The following is a description of a gene set: from publication Shinohara H, Behar M, Inoue K, Hiroshima M, Yasuda T, Nagashima T, Kimura S, Sanjo H, Maeda S, Yumoto N, Ki S, Akira S, Sako Y, Hoffmann A, Kurosaki T, Okada-Hatakeyama M (PMID 24833394) Human Gene Set: GSE41176_WT_VS_TAK1_KO_ANTI_IGM_STIM_BCELL_6H_DN studied in species Homo sapiens Genes down-regulated in B lymphocytes treated by anti IgM for 6h: wildtype versus MAP3K7 knockout. The activation signaling of transcription factor nuclear factor-kB (NF-kB) plays central role for immune system. One of key kinase mediating this pathway is TAK1 in adaptive and innate immunity. However, role of TAK1 in B cell receptor signaling is still unclear. To know effects of TAK1-deletion on the gene expression induced by anti-IgM, we performed the time course analysis in comparison of wild type with TAK1-deleted splenic B cells., and this is the list of marker genes: PLSCR1, PTPN6, PATZ1, COPS7A, FH, TRAF3IP2, RIPK2, DENND4A, ZNF10, SUCLA2, HCAR3, STAT1, RAC2, IFNGR2, IVNS1ABP, IFNGR1, M6PR, PFDN1, TADA3, SERBP1, RABGGTB, PTGS2, FLOT1, ADAMDEC1, TNFAIP3, PIM2, UTP3, TNIP1, RIN2, COQ2, C3AR1, PDHX, KYNU, CYRIA, RAD23A, GCH1, SHMT2, IL4R, FCHSD2, RPE, CLK2, DNAJC11, DDX18, ACO1, SUSD6, IFNAR2, NBN, TRAFD1, ADAR, TUBB, EIF3M, TFEC, BECN1, B2M, IL2RG, VPS11, PTX3, SERPINB9, LSS, GGCT, SERPINB1 (NCBI Gene Id 1992), BIRC3, RUVBL2, TFRC, BATF, CD80, INSIG1, ADORA2A, IKBKB, ANKS1A, CFLAR, BCL2A1, AK4, PISD (NCBI Gene Id 29838), NFKBIA, KCNMB1, IQGAP2, PUM3, PLD1, PSMA6, DMXL2, FNBP1, SASH1, DYRK3, KANK1, CDK4, NR3C1, NFKB1, STAT5A, ENG, MSC, ARFRP1, HCK, POLR1C, GBP1, SOCS3, ZNF175, ZC3H13, RAB3GAP1, ZFYVE26, GSDME, HDGF, DYNC1I2, TNFAIP8, CD40, NCAPD2, MRPL9, N4BP1, LYN, EIF2B2, C5orf15, ALDH9A1, IGSF6, NAB1, SMS, ADA, PTEN, LAMP3, TFDP1, BMS1, RHOQ, CRIM1, ACSL4, LPL, ACP2, RGS19, BTG3, MAP3K4, GRB2, RAB13, FLT1, FARSA, GGA3, CREBL2, CEP135, UBE2D1, NECAP1, ATP6V1H, CD69, CD44, POLR2J, ARAP1, GPSM3, SLC39A8, BBS4, PDE4B, ATP6AP1, NDUFV2, ZNF330, HAX1 (HCLS1 associated protein X-1), ITGA1, AMPD3, MAP3K5, TBC1D9, CASP1, CDK14, DUSP2, ALCAM, MLH1, RFTN1, ARFIP1, TNFRSF4, SLC11A2, PTAFR, AKAP10, CD47, DDX19B, LPP, ADGRE2 (adhesion G protein-coupled receptor E2), AQP9, IL18, MAK16, NUP188 (nucleoporin 188), LAIR1, ZBTB24, ATP6V0A2, CD48, GPR137B, PTPRJ, HLA-F, G0S2, SGPL1, ATP2C1, ATP6V1E1, RARS1, STAT4, BOLA2, AIMP2, GSK3B, EPM2AIP1 (NCBI Gene Id 9852), VAV1, EHD1, SLC7A7, CCL4, RIPOR2, OTUD4, PPP3CB, ARF3, CAMTA2